Given this list of marker genes SNX27, GKN1, HOXC10, DOCK1, AAMP, KCNMA1, MPP4, STXBP2 (NCBI Gene Id 6813), WDR47, ATP6V0B, MARF1, ACOT1, FMO5, ZFP28, SOSTDC1, AP2S1, SPSB1, MBTPS1, CFAP251, MCOLN1, KLHL25, PIGN, GTF3C5, LGR5, DDX50, TMEM47, PRCC, ROBO1, GGT1, BOD1, FOXP2, ERC2, ATPAF2, TYK2, ADAM15, NMB, KHDC4, CHD2, TCIRG1, RGL2, SLC38A7, GZMK, TSR3, SPTLC2, ZMYND8, ARHGAP9, TBC1D17, PDXDC1, WWP2, PLEKHA2, FGFR1, SCAP, IGF1, RBM10, EXPH5, MPND, C4orf54, SIK3, INHBA, TNIP1 (NCBI Gene Id 10318), SPA17, PRKCZ, ICE1, CIAO3, HINT2, NUDT14 (nudix hydrolase 14), TUBGCP4, NAPRT, KIF13B, ACBD4, WDR91, TP53BP2, GGA1, CCDC51, FAR2, APH1B, BAIAP3, VEZT, CYP2C8, NR1H3, KRTAP2-4, ROCK2, TCP10L, PITPNM1, ADGB, PGR, LUZP2, SLC17A6, ANKRD7, TECRL, TRIM26, PRSS35, ACTR8 (actin related protein 8), TBC1D32, RHBDL1, CAPS2, BRWD3, PRDM10, C5orf46, CCP110, RLN1, VPS41, COL13A1, NEURL4, MCTP1, CYP3A7, MARK4, NBEAL2, PCDH18 (protocadherin 18), MYO3A, ABCC2, RBFOX1, HYAL3, WAS, TJP2, MTERF2 (mitochondrial transcription termination factor 2), AP1M2, ZYX, INTS8, GNAI1, LRGUK, HGS, IL11RA, ZNF48 (NCBI Gene Id 7599), SLC7A8, SLC23A3, NELL1, COL11A1, STX2, PEX11A, ANPEP (NCBI Gene Id 290), HPS4, UGT2B10, CCDC134, RHBDL2, KLF4, DPP9, NWD2, SERAC1, PDE7A, PCDHB16, CPA2, GASK1B, MAML2, HDAC5, YTHDC1, DCDC2, CADM2, LGI2, RPH3AL, RAB11FIP3, CHL1, GCN1, SPNS1, HSPA4L, CA3 (carbonic anhydrase 3), GLE1, CCND3, ALAS2, POLA2, HPX, SOX11, RLF, GRM7, OSMR, SH2D5, SRCAP, RASGRP2, TRAPPC2B, DDX41, BMP15, SLC20A1, STRN3, GDAP1 (NCBI Gene Id 54332), HSPA12A, TOX3, SPAM1, DNAJC8, SLC4A10, TRAPPC12, RIN3, GPR85, SLC2A10, PRF1 (NCBI Gene Id 5551), CADPS2, ACRV1, EPB41L3, SLC4A2, MID2, DMRT2, LANCL3, CLRN3, CCDC87, MYO19, TARBP2, TEPSIN, NPEPL1, PPP1R13B, PRR11, ATG4B, here is a description of the gene set: Human Gene Set: GSE28737_WT_VS_BCL6_HET_FOLLICULAR_BCELL_UP Bcl6 germline deletion causes a prominent inflammatory disease, owing to over-expression of Th2 cytokines, and affects the properties of B cells prior to immunization. Therefore we established the B cell-specific Bcl6 deletion mice and analyze the gene expression of naive B cells under physiological conditions. Genes up-regulated in follicular B lymphocytes: wildtype versus heterozygotic knockout of BCL6. from publication Kaji T, Ishige A, Hikida M, Taka J, Hijikata A, Kubo M, Nagashima T, Takahashi Y, Kurosaki T, Okada M, Ohara O, Rajewsky K, Takemori T (PMID 23027924) studied in species Homo sapiens